Given this list of marker genes Abcc3, Abcc2, Abca8a, Abcg2, Abcb1b (NCBI Gene Id 18669), Abca8b, Abcc6, Abcb11, Abcc10, Ralbp1, Abcc1, Abcc5, Abcb1a, Abcc4, Abca3, Abcb5, here is a description of the gene set: Mouse Gene Set: GOMF_ABC_TYPE_XENOBIOTIC_TRANSPORTER_ACTIVITY Catalysis of the reaction: ATP + H2O + xenobiotic(in) = ADP + phosphate + xenobiotic(out). species: Mus musculus